The following is a description of a gene set: from publication Amit I, Garber M, Chevrier N, Leite AP, Donner Y, Eisenhaure T, Guttman M, Grenier JK, Li W, Zuk O, Schubert LA, Birditt B, Shay T, Goren A, Zhang X, Smith Z, Deering R, McDonald RC, Cabili M, Bernstein BE, Rinn JL, Meissner A, Root DE, Hacohen N, Regev A (PMID 19729616) Genes up-regulated in comparison of dendritic cells (DC) stimulated with poly(I:C) (TLR3 agonist) at 1 h versus DC cells stimulated with Gardiquimod (TLR7 agonist) at 1 h. species: Homo sapiens mouse primary BMDCs were stimulated with tlr ligands and gene expression changes were profiled on Affymetrix arrays Human Gene Set: GSE17721_POLYIC_VS_GARDIQUIMOD_1H_BMDC_UP, and this is the list of marker genes: TNC, THBS2, MACROH2A1, ASB16, RGS2, CCDC82, ECSIT, SNAPC2, CCDC198, ZNF3, NAPA, MAU2, FBXO11, ECE1, RSPO1, SPINT1, CPSF1, INPP5B, HACD2, CUBN (cubilin), HCST, IL1RAPL2, TRIM25, MAGI2, ATP1B2, SPG7, XRN2, RPS11, TMEM176B, COMT, RNF34, HSD17B1, IRX6, RAPGEF1, CNPY2, BCL7C (NCBI Gene Id 9274), DPEP3, DTX2 (NCBI Gene Id 57652), STX8, RAPSN, SESN3, SMC4, FBXL8, EIF5, MOS, L1CAM, CELF1, MBP, CNN2 (calponin 2), MALAT1, GJD2, SUPT20H, KDM5C, NAA20, CACNG1, NEMF, CCDC59, FXYD1 (FXYD domain containing ion transport regulator 1), PRRX2, SFXN3, SPMIP5, TMED10, INO80, ADAM33, PIK3R1, ENTPD4, CUEDC2, FAH, CDX1, TNFSF8, GPC1, DCTN4, ORM1, NUDT1, COL4A4, STRBP, CDC37L1, RBM22, ONECUT1, AP2A2, TNRC6A, SMR3A, SLC6A17, BCL9L, DENND2D, GADD45G, ANXA11, ZYX, HJURP, C15orf40, CDKN2C, ZNF48, HS6ST2, ZNF704, PIK3CG, SHMT1, MAGI3, SPRY4, MICAL1, PDE6C, HPS3, PDLIM4, VAMP1, MMP23B, ABTB1, ACOT7, MAPK8IP2, EEF1B2, GJA8, AP1G2, FBH1, FUBP1, PRP4K, MRM1, ZNF436, THRAP3, RPL27, MRTFA, ARHGAP45, ZNF394, ANXA10, ZBTB20, SLC29A2, MEA1, WNK2, TRAF4, TCF4, S100A8, GFRA3, TCF20, KDELR2, KIF1B, DAZAP1, ASB5, KMT2A, STX4, PITPNM1, STMP1, HMG20B, GPANK1, SLC25A20, PCDHB5, DNAJC10, GLTP, SERPINF2, UNC45A, THOC2, WNT9B, SYS1, KDM5A, SH3BP2, REV1 (NCBI Gene Id 51455), NXF1, KLF10, ABHD8, COX19, RPL14, ANKZF1, GEMIN2, SERPINB1, BARX2, EGFL7, PLEKHA1, ZNF286A, NRDE2, NOL12, DIAPH2, NOTCH2, NECAP2, OAS3, ARPP19, FBN2, HSPA8, YPEL3, CAPN6, ATP13A2, ATXN7, RPL7, OSCAR (NCBI Gene Id 126014), CEP250, NLGN2, SPOCK2, TRIM7, PSMA3, YBX2, BMP2K, TRPV6, NCKAP1L, HIVEP3, DPP4, DAZAP2, SAPCD1, ARRB2, REXO4, CASP3, CAMKK2, ENPP1, PSTPIP2 (NCBI Gene Id 9078), KIF1A, SEPTIN2